The following is a description of a gene set: species: Mus musculus from publication Howe DG, Blake JA, Bradford YM, Bult CJ, Calvi BR, Engel SR, Kadin JA, Kaufman TC, Kishore R, Laulederkind SJF, Lewis SE, Moxon SAT, Richardson JE, Smith C (PMID 30224793) Mouse Gene Set: HALLMARK_XENOBIOTIC_METABOLISM Mouse genes annotated to HALLMARK_XENOBIOTIC_METABOLISM based on orthology mappings provided by the Alliance Genome Consortium, and this is the list of marker genes: Slc6a12, Tgfb2, Slc1a5, Gclc, Lcat, Hmox1, Arg2, Acox2, Upb1, Npc1, Sertad1, Smox, Cda, Ahcyl, Reg1, Marchf6, Atoh8, Adh7, Spint2, Hrg, Gcnt2, Tmem176b, Mthfd1, Por, Casp6, Gch1, Gss, Cyp26a1, Itih1, Blvrb, Cyfip2, Dhrs7, Ets2, Epha2, Acox3, Hacl1, Ap4b1, Igfbp4, Pdlim5, Mccc2, Alas1, Crp, Ddc, Entpd5, Ddt, Ninj1, Ttpa, Ptges3-ps, Cyb5a, Gstt2, Nmt1, Ugdh (NCBI Gene Id 22235), Asl, Ptges, Apoe, Itih4, Nfs1, Pdk4, Tnfrsf1a, Vnn1, F10, F11, Kynu, Tat, Ccl25, Gstm4, Igf1, Cyp2e1, Pgd, Bcar1, Tmbim6, Akr1c6, Pink1, Ces1d, Gckr, Tkfc, Hnf4a, Esr1, Crot (NCBI Gene Id 74114), Hsd11b1 (hydroxysteroid 11-beta dehydrogenase 1), Acp2 (NCBI Gene Id 11432), Id2, Adh5, Rbp4 (retinol binding protein 4, plasma), Cyp4f14, Pros1, Fmo3, Pcx, Plg, Cyp17a1, Slc35b1, Mpp2, Acox1, Pemt, Aqp9, Rap1gap, Gsr, Etfdh, Ndrg2, Sar1b, Vtn, Tpst1, Tmem97, Cndp2, Hprt1 (NCBI Gene Id 97612), Comt, Dcxr, Abcc2, Abcd2, Ptgds, Car2, Angptl3, Shmt2, Pmm1, Hes6, Atp2a2, Cat, Jup, Slc22a1, G6pc1, Bphl, Pgrmc1, Cdo1, Cyp1a2, Slc35d1, Cyp27a1, Irf8, Fmo1, Mbl2, Lpin2, Tdo2, Fbln1, Arg1, Fabp1, Aldh9a1, Idh1, Lonp1, Dhps, Aco2, Cfb, Cbr1, Maoa, Dhrs1, Arpp19, Retsat, Serpina6, Upp1, Acp1, Pts, Hgfac (hepatocyte growth factor activator), Abhd6, Bcat1, Xdh, Fetub, Slc6a6, Aox1, Pycr1, Cd36, Acsm1, Serpine1, Gsto1, Aldh3a1, Gad1, Psmb10, Man1a, Ddah2, Igfbp1, Kars1, Slc46a3 (solute carrier family 46, member 3), Cyp2j6, Gart, Csad, Nqo1, Fas, Leap2, Elovl5, Il1r1, Aldh2 (NCBI Gene Id 11669), Papss2, Fbp1, Ppard, Ssr3, Cyp2c55, Gnmt, Slc12a4, Ephx1, Ech1, Cyp1a1, Ptgr1, Cyp2s1, Enpep, Fah, Hsd17b2, Tyr, Gabarapl1, Abcc3